Given this list of marker genes Bmp4, Nr3c1, Aqp1, Epha5, Hnf1a, Sgk1, Npas4, Ucp1, Cdc5l, Adcy6, Msn, Ifnb1, Fbp1, Klf4, Crh, Cftr, Mettl21c, Abcb1a, Ptgdr, Sox10, Nanog, Postn, Foxo1, Cdk4 (NCBI Gene Id 12567), Bmi1, P2ry4, Tnfsf4, Cdc5lrt7, Ptgfr, Adcy8, Ptger4, Scnn1a, Trerf1, Prkaa2, Cdc5lrt10, Gjb2, Ace, Ugt3a1, Efna5, Tnc, Fos, Acod1, Scnn1b, Klf2, P2ry6, Scnn1g, Arpc2, Nr3c2, Akr1b1, Spp1, Mir21a (microRNA 21a), Rps6kb1, Sphk2, Cdc5lrt8, Klf9, Trim63, Map4k1, Akap8, Tbx2, Rwdd1, Acaca (acetyl-Coenzyme A carboxylase alpha), Cyp1b1, Casp9, Adcy1, Agtr2 (NCBI Gene Id 11609), Fech, Serpinf1, Adcy5, Hnrnpu, Smyd3, Gnas, Ptger2, Agtr1a, Agtr1b, Tgfb1, Park7, Elk1, Axin2, Fbxo32, Gnai1, Prkaa1, Ptger3, Gas6, Mup1, Rplp0, Sirt1, Akr1c18, Fdx1, Mup11, Rnf4, Adam15, Adcy3, Sfrp1, Src, Golph3, Cdc5lrt1, Cdc5lrt5, Vps54, Gdnf (NCBI Gene Id 14573), Pax6, Aifm1, Slc5a5, Btg2, Mir155, Larp1, Akt1, Adcy2, Foxo3, Hnrnpk, Egfr (NCBI Gene Id 13649), Jak2, Ahr, Ddit4, Ugt3a2, Atp5f1a, Cdc5lrt6, Creb1, Cdc5lrt9 (NCBI Gene Id 668213), Prkd1, Slc39a9, Rock2, Pck1, Star, Ccl2, Hdac8, Eif4ebp1, Eif4e, Pck2, Mstn, Prkce, Cdc5lrt4, Ar, Grip1, Ass1, here is a description of the gene set: species: Mus musculus Any process that results in a change in state or activity of a cell (in terms of movement, secretion, enzyme production, gene expression, etc.) as a result of a ketone stimulus. Mouse Gene Set: GOBP_CELLULAR_RESPONSE_TO_KETONE